Given this list of marker genes NUDC, CSTF2, HK1, ORC6, KCTD3, IPP, SORBS3 (NCBI Gene Id 10174), BCL7C, BHLHE40, SLC25A47, NUP133, HPRT1 (hypoxanthine phosphoribosyltransferase 1), CMSS1, SEPTIN8 (septin 8), SLC25A38, AURKB, EIF4B, TEX29, LIN9, PCYT1A (NCBI Gene Id 5130), ACSL3, KIAA1958, ADAM9, HOOK2, ANP32B, RNF24, MATCAP2, ANKRD49, MRPS2, UNC93B1, HES3, CKAP2L, SUV39H1, HP, DNMT3B, TFDP2, GSE1, CUEDC2, ATPAF2, PITHD1, NUP107, HEBP2, TBCCD1, OPN3 (NCBI Gene Id 23596), ACSS1, ATP2A2, AUNIP, RHBDD3, FDPS, TVP23B, TCEAL1, LTBR, MGAT5, IARS1, STRBP, TUFT1, TWSG1, CITED4, MRPL27, NFAM1, DMWD, ERLIN2, CTC1, GNG3, NRM, YPEL2, PRC1 (protein regulator of cytokinesis 1), HCN3, HNRNPLL, PHGDH, PPM1G, ORC3, EXOC7, SOX8, LRRC41, DHFR, CDK2, GEMIN8, AQP9, CCNE2, SGCE, DYNLT2B, HMMR, LMNA, PTGR2, NCF1, PLA2G6, TTC16, TRAP1, CRYZ, HDGF, FADS1, TFCP2L1, FARSA, TPM2, CDCA2, RAD1, TRMT6, CPT2, WRAP53, FAM181B, P4HB, SNX9, MRPL2, LDLRAD3, DHRS13, SMO, APP, CRIP2, QTRT1, HYCC1, AURKA, TMEM106C, LSM7, ZNHIT3, TMT1A, PPP1R8, IDI1, RCOR1, KNTC1, DHX33, NUP155, NIFK, ERBB3, PCLAF, CIAO3, ABCB6, HNRNPH1, ANAPC1, HSPA4L, CCDC51, TMEM9, DCTD, GRIK4, GEMIN6, ATL1, GAB2, RNPEP, FLNB, DEF8, ADGRL4, DIO2, SNCA, C11orf65, APRT (NCBI Gene Id 353), AGPAT5, RAMP1, ELAVL1, DOLK, TGIF2, DGCR8, PXMP2, ZNF771, SLC45A4, CDC25A (cell division cycle 25A), AK4, VWF, KANK3, MT1E, IPO5, SALL3, KIF3A, SWI5, ZFP41, DCAF10, MRPL3, INSIG1, TEK, GID4, LPCAT1, AFG2A, ERG, NCAPG2, CFAP418, NIP7, POLR1C, NBN, PTPRK, SMPD4, AGO4, NSD2, CXCL13, RPA3, TAS1R1, CEP83-DT, SLK, KDM1A, PSMB2, SPI1, RMND1, FIRRM, TMEM151A, RABGGTB, RHOBTB1, SGK3, ALOX5AP, GLA, POMT1, ST7, MRPL42, here is a description of the gene set: Genes up-regulated in comparison of lineage negative versus NKT cells. Human Gene Set: GSE27786_LIN_NEG_VS_NKTCELL_UP species: Homo sapiens from publication Konuma T, Nakamura S, Miyagi S, Negishi M, Chiba T, Oguro H, Yuan J, Mochizuki-Kashio M, Ichikawa H, Miyoshi H, Vidal M, Iwama A (PMID 21540074) Each fraction of mouse hematopoietic cells was purified by cell sorting from bone marrow of 8-week-old C57BL/6 mice, and its gene expression was analyzed.